The following is a description of a gene set: The actin-mediated process that results in the contraction of the apical end of a polarized columnar epithelial cell. Mouse Gene Set: GOBP_APICAL_CONSTRICTION species: Mus musculus, and this is the list of marker genes: Luzp1, Rock1, Ccdc88c, Pard3, Frmd6, Epb41l5